Given this list of marker genes SQSTM1, MT-TT, ALDH4A1, CLTRN, PSMD12, MYO7A, EPM2A, USH1C, SLC6A19, BCKDHA, CISD2, CYP27A1, BPTF, BRCA2, SNCAIP, EPCAM, OPA1, DEPDC5, TNFSF4 (TNF superfamily member 4), MTHFR, NPRL2, TBP, BMPR1A, PRKN, MOG, APOL4, PRNP (prion protein (Kanno blood group)), ALAD, PINK1, C9orf72, TTC19, ADGRV1, COMT, PRDM8, PIK3CA, CLRN1, CPOX, POLE, MMACHC, RELN, SNCB, FUS, TRRAP, NHLRC1, CTSH, TARDBP, ESPN, SLC2A3, ECM1, PPT1, EIF4G1, MAN2B1, RPS20, HLA-DRB1, ARSG, DNAJC6, GBA1, DCAF17, UPF3B, PMS2, MT-TS2, JPH3, MLH1, SPART, ATM, PMS1, SLC25A13, CEP85L, TGFBR2, GRN, SORL1, SNCA, HARS1, ATXN2, CACNA1A, DRD3, P2RY11, WFS1, UCHL1, ATXN8OS, APOL2, TOMM40, PUS3, MAPT, PDZD7, DNM1L (dynamin 1 like), P4HA2, CHCHD10, MSH2 (mutS homolog 2), TREM2 (triggering receptor expressed on myeloid cells 2), DNAJC5, CIB2, CDH23 (NCBI Gene Id 7395), PPOX (NCBI Gene Id 7440), PSEN2, CLN6, ARSA, VPS35, USH1G, CDH2, GIGYF2, ADH1C, PSEN1, ALDH5A1, KRAS, FIG4, NR4A2, HTR2A, ATP13A2, NPRL3, CSF1R, SEMA4A, FBXO7, USH2A, TRANK1, HLA-DQB1 (major histocompatibility complex, class II, DQ beta 1), LRRK2, MED12, LGI1, SON, HLA-B, PDGFRB, GCSH, WHRN (NCBI Gene Id 8016), ZNF365, PTPN22, TBK1, CHEK2, MUTYH, HTRA1, DNAJC13 (NCBI Gene Id 285196), MSH6, DAOA, HCRT, PARK7, APP, PSAP, ABCA7, HTRA2, SYNJ1, NDP, CHI3L1, PODXL, BCS1L, DNMT1, CEP78, ZDHHC9, TTR, POLD1, RTN4R, PCDH15, HTT, SYN2 (synapsin II), VCP, HMBS, ATP7B, CHCHD2, ATXN3, VPS13C, here is a description of the gene set: species: Homo sapiens Hallucinations Perceptions in a conscious and awake state that, in the absence of external stimuli, have qualities of real perception. These perceptions are vivid, substantial, and located in external objective space. Human Gene Set: HP_HALLUCINATIONS